Given this list of marker genes SNRPB, H2AX, DDX46, H3-3A, SNRPF, H2BC5, SF3A3, SF3B6, PUF60, TCF4, SF3A2, SNRPB2, SSRP1, SF3B4, H2AB1, H2BC13, H3C1, H2AZ2, H3C15, SF3A1, U2SURP, PAF1, H2BC21, DDX42, H2BC9, SF3B1, H2BC15, CTR9, LEO1, SF3B5, RTF1 (RTF1 homolog, Paf1/RNA polymerase II complex component), SNRPG, H2AC14, H2BC11, H2AC18, H2AC20, H2BC14, CHD1, CDC73, CHD2, H4C1 (H4 clustered histone 1), H2BC3, SNRPD1, PHF5A, SMNDC1, H2BC26, RBM17, TCF3, H2BC4, CHERP, SUPT16H, SNRPD2, H2AJ, H2AC4, MYOD1, H2AC7, SNRPA1, H2BC12, MYOG, H2BC1, DHX15, SNRPN, SF3B2, H2AC6, SF3B3, SKIC8, SNRPE, H2BC17, TCF12, H2BC12L, SNRPD3, here is a description of the gene set: studied in species Homo sapiens CHD subfamily I members CHD1 and CHD2 act as monomeric ATP-dependent chromatin remodellers. Human CHD1 and CHD2 are characterized by the presence of double chromodomains at the N-terminal, and central SNF2 helicase ATPase domain, and a C-terminal SANT-SLIDE DNA binding domain. They are 60% identical and 80% similar at the amino acid level but have significantly divergent C-terminal regions that may contribute to different functions. Both proteins have been shown to bind to H3K4me3, albeit with different affinities and to possess in vitro and in vivo ATP-dependent chromatin remodelling activity. Both proteins are associated with transcriptionally active regions of the genome and may play a role in histone H3.3 deposition. part of: CHD chromatin remodelers Reactome Pathway: CHD1 and CHD2 subfamily